Given this list of marker genes PIK3C3, PIK3R4, NHLRC1, BECN1, ATG14, UVRAG, EPM2A, here is a description of the gene set: Autophagy-vesicle nucleation/elongation/maturation, E3 ubiquitin-ligase Malin. Pathway ID: N01719. Pathway type: Reference. Pathway class: nt06532 Autophagy. Pathway Definition from KEGG: (EPM2A+NHLRC1) -> (BECN1,PIK3C3,PIK3R4,ATG14,UVRAG) Human Gene Set: KEGG_MEDICUS_REFERENCE_AUTOPHAGY_VESICLE_NUCLEATION_ELONGATION_MATURATION_E3_UBIQUITIN_LIGASE_MALIN species: Homo sapiens